Given this list of marker genes Dab2ip, Cd36, Tlr6, Ly96, Myd88, Tollip, Tirap, Tlr2, Saa3, Tlr1, Syk, Ceacam1, Unc93b1, here is a description of the gene set: species: Mus musculus Mouse Gene Set: GOMF_TOLL_LIKE_RECEPTOR_BINDING Binding to a Toll-like protein, a pattern recognition receptor that binds pattern motifs from a variety of microbial sources to initiate an innate immune response.